Given this list of marker genes ADAMTSL3, TPSAB1, OTOL1, TGM1, CCDC80, ADTRP, MIR24-1, APLP1, SCX, ADAMTS19, CRISPLD2, ERCC2, MIA, SLC39A8, EMILIN1, MIR195, CYP1B1, KLK4, RECK, MIR205, SPOCK2, COL6A5, MMP20, ADAMTS5, ABI3BP, COL22A1, FLOT1, COL11A1, POMGNT1, IER3IP1, POMT2, COL1A1, TGFBR3, FBLN5, COLQ, FERMT1, CMA1, MMP2, SH3PXD2B, GPM6B, ITGB1, DNAJB6, PDPN, TIMP3 (NCBI Gene Id 7078), CFLAR, ECM2, ANTXR1, TGFBR1, COL9A1, LRP1, CTSV, LUM, ANTXR2, DDR1, COL4A3, MIR9-1, WT1, ELF3, COMP, ABL1, ELN (elastin), MMP10, ADAMTS2, MMP21, COLGALT2, ST7, COL5A2, ADAMTSL2, PXDN, COL9A3, MIR29C, AGT, LOXL1, HAS2, AXIN2, FSCN1, TGFB1, HSD17B12, NTN4, SULF2, LOXL4, C6orf15, CAPG, RUNX1, MPZL3, GFAP, MMP23B, COL23A1, LOXL2, KLK5, ANGPTL7, EGFL6, PLG, KLK7, PLOD2, ZNF469, P3H4, MELTF, THSD4, GREM1, NPHS1, DDR2, ADAMTS16, ITGA8, COL11A2, COLGALT1, COL24A1, VPS33B, ATXN1L, TNXB, SELENON (NCBI Gene Id 7800), OLFML2A, FBLN1, CLASP2 (NCBI Gene Id 440948), SMAD4 (NCBI Gene Id 4089), FKRP, IMPG1, OLFML2B, BMP1, COL3A1, ADAMTSL5 (ADAMTS like 5), BMP2, MMP28, TCF15, ADAMTSL4, LOXL3, COL8A1, FKBP10, ERO1A, RIC8A, SERPINB5, MMP19, MIR19B1, HAS3, COL16A1, MMP1, HAPLN2, MMP25, ITGB3, COL4A6 (collagen type IV alpha 6 chain), PHLDB2, ADAM8, SMAD3, COL9A2, PRICKLE1, FURIN, ANXA2, DPP4, DMP1, MMP13, STAT3, ADAMTS18, FGFR4, RIC1, NR2E1, MFAP4, LOX, GSN, MIR92A1, VIPAS39, LAMB1, TMPRSS6, FMOD, ADAMTSL1, COL28A1, GAS6, LAMA2, PLOD3, MIR145, ADAMTS13 (ADAM metallopeptidase with thrombospondin type 1 motif 13), APBB2, MYH11, WASHC1, FLRT2, TNFRSF1B, COL1A2, COL15A1, APP, CTSK, SOX9, HMCN1, MMP11, CRTAP, POMT1, MMP9, FOXC1, CTSG, SPINT2, TIE1, NID2, COL4A5, PPARG, MATN2, ADAMTS7, LAMA1, VTN, MIR98, PBXIP1, FOXF2, VWA1, MMP8, ADAMTS17, KIF9, MMP26, MIR483, TGFBI, SMOC2, IHH, IBSP, PAPLN, ERO1B, FKTN, DPT, IL6, MIR21, COL10A1, MMP27, EGFLAM, CTSS, MYO1E, LTBP4, FOXC2 (NCBI Gene Id 50824), PRSS2, ATP7A, CCN1, MMP3, COL4A4, MATN1, ADAM15, COL2A1, WNT3A, TGFB2, COL27A1, EXOC8, CAV1, MMP15, CHADL, COL6A1, COL17A1, NOTCH1, VIT, SLC2A10 (solute carrier family 2 member 10), ENG, ELANE, COL4A2, MMP16, ADAMTS4, EFEMP2, FOXF1, CARMIL2, HRNR, NFKB2, MMP12, MIR27B, MMP7, MMP14 (matrix metallopeptidase 14), ADAMTS6, COL19A1, CLASP1, COL5A3, SERPINF2, MANSC4, NPHP3, CST3, PHLDB1, ADAMTS14, ADAMTS3, PRDM5, LAMB2 (NCBI Gene Id 3913), COL18A1, GAS2, TNF, PDGFRA, SMPD3, NDNF (NCBI Gene Id 79625), COL14A1, BCL3, QSOX1, SULF1, FSHR, PTX3, RAMP2, ADAM10, P3H1, AEBP1, COL6A6, COL4A1 (NCBI Gene Id 1282), ADAMTS10, TMEM38B, TLL2, COL7A1, NOX1, SMOC1, LAMC1, ADAMTS1, MATN4, CSGALNACT1, HAS1, P4HA3, DAG1, RGCC, CAV2, MATN3, MMP24, ADAMTS20, TNFRSF11B, ITGA2, SERPINH1, COL5A1, MIR19A, TLL1, ADAMTS15, IMPG2, MPV17, NPNT, LCP1, B4GALT1, CREB3L1, LARGE1 (LARGE xylosyl- and glucuronyltransferase 1), MYF5, SPINK5, EXT1, PRDX4, OPTC, NOXO1, NF1, SERAC1, SPINT1, SFRP2, COL13A1, MIR18A, P4HA1, PRSS1, FAP, TNR, POSTN, HPSE2, GFOD2, RB1, ADAMTS8, PLOD1, COL12A1, HPN, MIR29B1, RXFP1, ADAMTS9, TNFRSF1A, MMP17, COL8A2, KAZALD1, ADAMTS12, NID1, here is a description of the gene set: A process that is carried out at the cellular level which results in the assembly, arrangement of constituent parts, or disassembly of external structures that lie outside the plasma membrane and surround the entire cell. species: Homo sapiens Human Gene Set: GOBP_EXTERNAL_ENCAPSULATING_STRUCTURE_ORGANIZATION